Given this list of marker genes DEF6, ARAP1, NCF4, ARHGAP45, SOS2, PKN2, NHS, ABI2, PAK3, NISCH, GNA13, SRGAP2, ALS2, GARRE1, CDC42BPA, ABL2, RAB7A, EMD, ARHGAP26, ARHGEF18, KALRN, FAM13B, PLEKHG6, ARHGAP23, IQGAP3 (NCBI Gene Id 128239), TAGAP, SPATA13, ARAP3, PLEKHG3, GIT1, YKT6, KTN1, NOXO1, PARD6A, RALBP1, PIK3CA (NCBI Gene Id 5290, phosphatidylinositol-4,5-bisphosphate 3-kinase catalytic subunit alpha), ARHGEF6, ARHGAP35, ARHGEF39, ABR, CDC42EP1, JAG1, FERMT2, ERBIN, ARHGAP22, VAV1, VRK2, SWAP70, DOCK10, MPP7, CYBB, MCF2L, ARHGAP15, CYBA, CYFIP1, WASL (WASP like actin nucleation promoting factor), VAMP3, CYFIP2, DOCK6, PKN1, CIT, IQGAP1, BAIAP2, ARHGAP42, DOCK2, LAMTOR1, WAS, ARHGAP27, ARHGEF11, CAV1, ARHGEF7, SOS1, FARP1, ARHGAP39, TFRC, ECT2, CHN1 (chimerin 1), ARHGEF4, ARHGEF25, DOCK3, EPHA2, PAK1, CDC42, FARP2, ARHGDIA, PREX2, ARHGEF10, VAV3, DOCK1, PIK3R3, BAIAP2L1, ARHGAP30, GMIP, ARHGAP4, WASF1, PAK5, ARHGAP20, NCF1 (neutrophil cytosolic factor 1), DOCK5, RACGAP1, ARHGAP44, ARHGAP1, SLC1A5, VAV2, SYDE2, DIAPH3, ARHGAP24, WASF2, PAK4, TAOK3, NOXA1, CDC42EP4, SNAP23, WIPF3, IQGAP2, FGD5, ARHGAP17, PREX1, TIAM1, ARHGEF5, TIAM2 (TIAM Rac1 associated GEF 2), DOCK11, ARHGDIB, WASF3, AMIGO2, DOCK4, NCKAP1L, ARHGAP9, FAM13A, PIK3R2, DOCK9 (dedicator of cytokinesis 9), MCF2, OPHN1, ARHGAP25, RASGRF2, FMNL1, VANGL1, ITGB1, SRGAP3, DEPDC1B, PAK2, WIPF1, ARHGAP10, LBR, NOX3, SRGAP1, ARHGAP32, NCKAP1, ABI1, ARHGAP29, ARHGEF19, BCR, ARHGEF15, PLD2, WIPF2, RAC1, DOCK8, PLEKHG1, PLEKHG2, ARHGAP12, GIT2, ARAP2, SH3BP1, DLC1, PIK3R1, TMPO, ARHGAP33, MCAM, NCF2, MYO9B, ARHGAP5, PAK6, PLD1, ESYT1, BRK1, NOX1, NGEF, LEMD3, CHN2, TRIO, DOCK7, ARHGAP21, PLEKHG4, ARHGAP31, here is a description of the gene set: studied in species Homo sapiens Human Gene Set: REACTOME_RAC1_GTPASE_CYCLE RAC1 GTPase cycle